Given this list of marker genes PHF19, SERTAD3, WWC3, TMEM176A, SPATA20, TMEM200A, SLC4A1AP, SCGB2B2, TRMT61A (NCBI Gene Id 414769), SESN2, ZNF473, RCCD1, RAD54L2, SNORD53, UBIAD1, TNIP2, ZRANB1, OR52A1, UBR7, POP7, TPST2, PHF8, VPS18, SLC31A1, SLC26A8, SMARCA1, TTC14, SHISA7, SMARCA4, PLBD1, SET, TBC1D20, PHB1 (prohibitin 1), TEX9, PCBP2, ZBTB34, TMPRSS3, PUS7, SETDB2, PHTF2, SLX4, SLC3A2, SIAH1, YAP1, SNORD42A, PITPNM1, SOD2, OGN, REC8, OSGIN1, OPN5, TMEM163, ZNF34 (NCBI Gene Id 80778), ZNF773, OR1L1, TIMP3, PGP, ZNF749, ZBED5 (zinc finger BED-type containing 5), TCIRG1, PCDHB14, SPRR4, GATD1, TXN, VWA5A, RTF1, SQLE, SNW1, PRPS1, RAB3GAP1, SLC2A10, THAP4 (NCBI Gene Id 51078), ZCCHC14, TUBB2A, OR6C74, PDXK, SLC35F2, DISP3, WNT5A, SH3BP5, PDCD6IP, PDC, RECQL4, SLC45A4 (solute carrier family 45 member 4), TMEM218, PLBD2, XDH, SHCBP1L, SUMO3, PRKCD, SETD5, ZDHHC11, VSTM1, SUGT1, PRSS33, TLR5, SPRR2E, TKT, SP3, SH3GL1, RAP1GAP2, SEC14L1, RD3, SLC25A45, ZYX, PPP1R18, TBC1D24, UPP1, STAM2 (signal transducing adaptor molecule 2), OR56B4, ZNF70, S100A3, TGFB3, TMEM59L, VIM, PKN1, SLC39A3, PFDN6, OSBPL11, SLC9A4, SLC14A2, TXNDC15, ZNF592, RBPMS, USP20, YIPF5, RAB34, TXNDC16 (NCBI Gene Id 57544), SLC6A20, RFX5, PPIAP26, PHTF1, SYNJ2, PLEKHB2, TEX13B, TNFRSF19 (NCBI Gene Id 55504), SLC43A1, SYCP2L, SIRT3, PRPF8, PIP5K1B, RNF6 (ring finger protein 6), RPL28, PARP4 (poly(ADP-ribose) polymerase family member 4), RGL2, SLC10A6, RAMP3, TAF9B, SALL2, TMEM132E, ZNF672, POP5, TSPAN5 (NCBI Gene Id 10098), TMEM231, ZBTB39, SESTD1, RAB5C, SUZ12P1, TBC1D4, PPM1J, PPP1R1C, MAP3K19, XRCC5, TMEM237, PDAP1, PPP3R2, SMC4, TMEM72, PSMA1, SNORA14B, TRAF3, SNX25 (NCBI Gene Id 83891), OR2L8, PPP1R9B, REEP3, MRM3, PFKFB1, TTC22, PNPLA2 (patatin like phospholipase domain containing 2), PCDHB8, NEMP2, TDRD12, ZMAT2, YTHDC2, ZNF341, SP1, KMT5A, TUBA1B, XRN1, RHOF, PRDX4, SCARNA14, RMND1 (required for meiotic nuclear division 1 homolog), ZNF808, SFT2D3, SLC37A3, ZNF836, SLCO3A1, OR14C36, ZNF620, here is a description of the gene set: Genes down-regulated in CD4 single positive cells: immature versus thymocytes. from publication Dik WA, Pike-Overzet K, Weerkamp F, de Ridder D, de Haas EF, Baert MR, van der Spek P, Koster EE, Reinders MJ, van Dongen JJ, Langerak AW, Staal FJ (PMID 15928199) T cells develop from progenitors that migrate from the bone marrow into the thymus. Thymocytes are subdivided roughly as being double negative (DN), double positive (DP), or single positive (SP), based on the expression of the CD4 and CD8 coreceptors. The DN stage is heterogeneous and can be subdivided into four distinct subsets in mice based on the expression of CD44 and CD25. In human, three distinct DN stages can be recognized: a CD34+CD38−CD1a− stage that represents the most immature thymic subset and the consecutive CD34+CD38+CD1a− and CD34+CD38+CD1a+ stages. Human DN thymocytes mature via an immature single positive (ISP CD4+) and a DP stage into CD4+ or CD8+ SP T cells that express functional T cell receptors (TCR) and that exit the thymus. In this study, gene expression was measured in each of these nine stages. Human Gene Set: GSE22601_IMMATURE_CD4_SINGLE_POSITIVE_VS_CD4_SINGLE_POSITIVE_THYMOCYTE_DN species: Homo sapiens